The following is a description of a gene set: Human Gene Set: HP_GENERALIZED_DYSTONIA studied in species Homo sapiens A type of dystonia that affects all or most of the body. Generalized dystonia, and this is the list of marker genes: ACTB (NCBI Gene Id 60), TUBB4A, AOPEP, NDUFA2 (NCBI Gene Id 4695), NDUFAF6, FA2H, SLC39A14, DLAT, LRPPRC, TSPOAP1, PLP1, NR4A2, ATP5F1A, UFC1, TIMM8A, VPS41, GCH1, THAP1, HPCA, IMPDH2, NUP54, ALS2, SUOX, PANK2, C19orf12, MRPS25, NAXD, KMT2B, CHD8, JAM2, TH, COQ4, PRKRA, TOR1A, TNR